Given this list of marker genes BCKDHB, CA13, CMPK1, TAPBPL, SHFL, ALKBH3, KIF21B (kinesin family member 21B), DNAJB11, UBLCP1, DNAJC2, FAM120A, NUBP2, CACNB4, MED1, HSPA1B, CD180, OAS1, HK2, GDI1, SEC24B, PSME1, LSP1, POGLUT1, CHFR, SLFN12L, BID, TMEM268, NMI, GUK1, PLAT, SLAMF1, PODXL, DPP3, MT2A, PDCD1LG2, LZTFL1, SLIRP, TMEM214 (NCBI Gene Id 54867), DNM1L, KCTD14, GMPPB, ABCB1, RMC1, FZD9, NGEF, M1AP, NT5C3A, BUB1B, TRIM25, DGKA, YPEL5 (yippee like 5), CSAD, PTGER2, LTA (lymphotoxin alpha), NUP50, INPP1, ASAH2, RRAGD, CLSTN1, TNFSF8, COMMD7, CDC37, NMNAT1, HHAT, BMS1 (NCBI Gene Id 9790), NRBP1, LFNG, TPBG, CTTN, NLGN2, TULP1, GYPC, IFT27, PMVK, LRRC8A (leucine rich repeat containing 8 VRAC subunit A), TYK2, SLC25A20, SLC6A4, TBC1D22A, PNRC1, ISOC1, SMAP2, DAB2IP, GPR182, SP110, ARHGEF10L, CCL5, PDCD6, NCOA3, UBE2M, HK1, GFRA4 (NCBI Gene Id 64096), IFIT2, NRROS, NOC2L, EXOSC9, IFI27L2, RNASEL, BFAR, KANSL2, GNB3, ACYP2, JDP2, FABP4, COPG2, PGS1, TMEM63B, RBM15, GNPNAT1 (glucosamine-phosphate N-acetyltransferase 1), LAD1, RCC2, SREBF1 (sterol regulatory element binding transcription factor 1), APMAP, EXOC7, CXCL9, GALNT10, INSL6, CLIC4, TADA3, TMBIM6, TOR1AIP2, IFT81, TPX2, SDC4, MACROH2A1, PDCD2, SH3GL1, POU3F2, CIITA, GUCD1, MYO10, TMEM30A, SLC2A8, ENOX2, RPAP1, MYH6, TAGLN2, UBTD1, TLR3, DBNL, EBI3, KCNIP3, TNFRSF1A, SLCO3A1, KEAP1, YIPF3, ENPP2, SHBG, MSANTD4, SERPINE1, AP3B2, ATP1B3, HTATIP2, GNG11, ITGA2B, CHAC2, BCL3, SOX12, RAB20, PRELID3B, PTEN, VRK2, PXMP2, ACTR1A, GSTT1, ANKFY1, KDR, FBLIM1, CDA (NCBI Gene Id 978), FPR3, STK39, NFKBIB, D2HGDH, CLDN3, PSENEN, COX20, TRIM21, C3orf38, IGBP1, TMEM37, EXOC6, GLB1, SHMT1 (NCBI Gene Id 9316), SCN3B, DENR, BLOC1S6, TSPYL1, TMEM140, AIDA, SELENOW, TRIM60, RAD23A, USP53, RAB22A, H2AC25, SAMHD1, AP2B1, CD40, P2RX5, here is a description of the gene set: species: Homo sapiens Genes up-regulated in comparison of dendritic cells (DC) stimulated with LPS (TLR4 agonist) at 12 h versus DC cells stimulated with Gardiquimod (TLR7 agonist) at 12 h. mouse primary BMDCs were stimulated with tlr ligands and gene expression changes were profiled on Affymetrix arrays Human Gene Set: GSE17721_LPS_VS_GARDIQUIMOD_12H_BMDC_UP from publication Amit I, Garber M, Chevrier N, Leite AP, Donner Y, Eisenhaure T, Guttman M, Grenier JK, Li W, Zuk O, Schubert LA, Birditt B, Shay T, Goren A, Zhang X, Smith Z, Deering R, McDonald RC, Cabili M, Bernstein BE, Rinn JL, Meissner A, Root DE, Hacohen N, Regev A (PMID 19729616)